The following is a description of a gene set: Distal amyotrophy Muscular atrophy affecting muscles in the distal portions of the extremities. Human Gene Set: HP_DISTAL_AMYOTROPHY studied in species Homo sapiens, and this is the list of marker genes: SMN1, SLC39A13, TWNK, NDUFA9, PRPH, PIK3R5, ATXN3, CHCHD10, ANG, SLC5A6, INF2, SLC52A3, JPH1, CCNF, TBCE, SYT2, SLC5A7, ABCA1, COMP, SPAST, HSPB8, SETX, IBA57, MYH7 (NCBI Gene Id 8090), TRIM2, TIA1, ATXN1, MUSK, SDHA, MME, ASAH1, SPG11, PNKP, FLRT1, TIMM8A, COA7, NEMF, SLC12A6 (solute carrier family 12 member 6), AFG3L2, RTN2, GLT8D1, UBQLN2, POMGNT2, LRSAM1, PDK3, GDAP1, TFG, LMNA, OPTN, PON1, TDP1, ZBTB20, JAG1, ZFYVE26, FGD4, FXN, GBF1, RAB7A, SPTLC2, SIGMAR1, KIF1C, CPT1C, TAF15, PON2, KIF5A, NGLY1, ATL1, ATAD3A, VPS13A, GIPC1, AIFM1, UNC13A, HSPB3, GLE1, MT-TE, REEP1, CAV3, HINT1, CADM3, VCP, UBAP2L, ATL3, DOK7, FUS, NEK1, ITPR3, SPTBN4, SLC25A46, SDHAF1, BICD2, KLHL9, ALDH18A1, AARS1, CCT5, ACTN2, PEX10, POLG, KDM5C, TYMP, CEP126, KLC2, MFN2, TPM3, PHKA1, BSCL2, VAPB, FBLN5, MED25, MPV17, EGR2, FLNC, GAN, TBK1, VPS13D, ANO5, MYOT, PLOD3, SPART (NCBI Gene Id 23111), GBA2, HARS1, AGL, HK1, SLC25A1, NEB (nebulin), DCAF8, WARS1, COL13A1, ADAMTS15, NEFH, DNM2, C19orf12, RAI1, TBCK, SNAP25, AGRN, KIF1B, CUL4B, NDRG1, CHRNA1, SACS, SVBP, SOD1, NOTCH2NLC, KIF1A, PMP22, COASY, PTRHD1, PON3, DCTN1, B4GALNT1, CHAT, FIG4, SDHD, PTRH2, SH3TC2, DAO, LITAF, SLC25A21, ATP7A, KRT5 (NCBI Gene Id 3852), MPZ, MAG, MRE11 (MRE11 homolog, double strand break repair nuclease), PLEKHG5, CFAP410, YY1, MSTO1, SBF2, MTRFR, COL6A1, YARS1, PMP2, ANXA11 (annexin A11), ALS2, GARS1 (NCBI Gene Id 7972), MARS1, SPTLC1, ATXN2, HSPB1, NEFL, TARDBP, ADSS1, TNR, PRPS1, VRK1, STUB1, CPLANE1, PNPLA6, GNB4, GJB1, LDB3, TTN, ATP1A1, MYH14, DNAJB2, SQSTM1, HNRNPA1, KANSL1, PPARGC1A, MYO9A, KRT14, APTX, TREM2, RILPL1, SLC18A3, GNE, MTMR2, SMN2, IGHMBP2, TCAP, VAMP1, TRPV4, CHMP2B, MATR3, ADCY6, RYR1, ACTA1, DYSF, TOR1AIP1, SOX10, SDHB, LRP12, ABHD12, ZC4H2, MORC2, CHP1, PRX, PFN1, SPTAN1, ERBB4, IDUA, CYP27A1, SCO2